Given this list of marker genes GPX8, AKR1B1, RANBP6, NOP9, ZBTB14, GTPBP10, AZI2, VGLL4, PCDHA13, KIRREL1, AGAP4, LRRC38, PCDHA3, DCTN2, COBL, SEMA4A, PCDHA6, YWHAE, PCDHA4, SOX8, THSD7B, MAP3K2, PCDHA8, CCDC39, NGFR, LRP4, VPS54, RPA1, ARL3, AGAP6, PIGG (phosphatidylinositol glycan anchor biosynthesis class G (EMM blood group)), AGAP9, PTEN, PCDHA7, FKTN, AP3D1, SELENON, CRIM1, YIPF4, PCDHAC1, MAN1A2, ENPEP, PCDHA2, SMOC2, PCDHA5, PCDHA12, IFIT2, ARHGEF17, RHOF, BTBD10, KDM5C, TFB1M, ERRFI1, TRAK2, FSCN1, PKDREJ, ANKRD27 (ankyrin repeat domain 27), NIF3L1, STON1, TNFSF10, VGLL2, IP6K3, TERF2IP, GASK1B, CNOT2, AP4B1, SFSWAP, ZNF485, COMT, TUBE1, DOCK3, AGAP11, NDRG2, TAX1BP1, SLC7A6, GPCPD1, PLEKHG1, FGFR1, CHD1, RNF170 (NCBI Gene Id 96586), PCDHA1, F8 (coagulation factor VIII), ATP6V1A, EEPD1, NR3C1, AGAP5, CTNND2, ZNF280A, NLGN4Y, LTA, RAB5C, PCDHA11, RTL5, NFKB1, CPPED1, LAMA3, PCDHAC2, MAB21L1 (mab-21 like 1), TECRL, INVS, ADAM21, PCYT1B, POLH, GPR3, BCL11B, PCDHA10, CDK8, SLC25A5, LDLRAP1, SENP1, TRPC5OS, here is a description of the gene set: Genes predicted to be targets of miRBase v22 microRNA hsa-miR-6801-5p in miRDB v6.0 with MirTarget v4 prediction scores > 80 (high confidence targets). studied in species Homo sapiens from publication Chen Y, Wang X (PMID 31504780) Human Gene Set: MIR6801_5P